Given this list of marker genes ZP2, ZP3, ADAM21, ZP1, SPAM1, OVGP1, ZP4, B4GALT1, ADAM20, ADAM2, ADAM30, here is a description of the gene set: part of: Fertilization studied in species Homo sapiens A typical mammalian egg is surrounded by an outer layer of about 3,000 cumulus cells embedded in an extracellular matrix rich in hyaluronic acid. It is suggested that the fertilizing sperm with it's acrosome intact, passes through the cumulus cell layer. The zona pellucida (ZP), a glycoproteinaceous matrix surrounding the mammalian oocyte plays an important role in species specific sperm-egg binding, induction of acrosome reaction in the ZP bound spermatozoa, avoidance of polyspermy and protection of the embryo prior to implantation. The human ZP matrix is composed of 4 glycoproteins designated as ZP1, ZP2, ZP3 and ZP4. Reactome Pathway: Interaction With Cumulus Cells And The Zona Pellucida